The following is a description of a gene set: Human Gene Set: HP_THIN_EYEBROW Decreased diameter of eyebrow hairs. Thin eyebrow studied in species Homo sapiens, and this is the list of marker genes: SLC1A3, KDM4B, RNU4ATAC, EPS8L3, MBTPS2, CDC45, BCL11B, ATP1A2, STAG1, RBL2, AASS, PEX6, DHX30 (NCBI Gene Id 22907), KAT6A, CACNA1A, CCNK, UBE3B, AEBP1, KREMEN1, TRPS1, ASXL3, CRELD1, PEX1, ATP1A3, TGDS